The following is a description of a gene set: Genes up-regulated at the peak of an antigen response of naive CD8+ T-cells. from publication Goldrath AW, Luckey CJ, Park R, Benoist C, Mathis D (PMID 15548615) studied in species Mus musculus Mouse Gene Set: GOLDRATH_ANTIGEN_RESPONSE Naive T cells proliferate independently of cognate antigen when introduced into lymphopenic hosts. Lymphopenia-induced proliferation depends on low-affinity MHC/self-peptide complexes and on IL-7. To elucidate the intracellular signals mediating this proliferation, we analyzed changes in gene expression in naive CD8+ T cells at different times after their transfer into a lymphopenic environment. The genes induced in response to lymphopenia were largely an attenuated subset of those turned up by full antigenic stimulation, including genes related to cell cycling, whereas excluding genes specifically associated with effector activity. After the initial phase of proliferation in an empty compartment, the naive T cells adopted a stable pattern of gene expression similar to that of antigen-experienced memory cells. Thus, T cells proliferating in lymphopenic hosts do not exhibit a unique gene-expression profile, instead relying on traditional signals for this antigen-independent proliferation; this process ultimately results in differentiation to authentic memory cells., and this is the list of marker genes: Myo1f, Lgals1, Cdk2ap1, Tbl2, Trappc1, Lgals3, Hopx, Vcl, Ccdc50, Tmem97, Kpna2, Rfc5, Tk1, Rbm3 (NCBI Gene Id 72067), Perp, Chek1, Ccnb2, Arl5a, Top2a, Ptger4, Siva1, Emp3, Crmp1, Il2ra, Etfb, H2-Aa, Hat1, Gpr137b-ps, Zfp207, Errfi1, Lmnb1, Mis18bp1, Dock5, Batf3, Brip1os, Carhsp1, Rrm2, Ccl5, Topbp1, Gem, Incenp, Iglc2, Itm2b, Alad, Fasl, Lyl1, Tmem14c (transmembrane protein 14C), Stard10, 1810037I17Rik, Irf4, Lat2, Krtcap2, Igkv1-135, Lxn, Sqle, Ahnak, Plscr1, Syce2, Hspa2, Ezh2, Gzmk, Tceal9, H2az1, Fignl1, Bub1, Pim1, Cd44, Polr3k, Prim2, Slc31a1, H3c8, Cdk1, Stmn1, Tyrobp, Gnpda1, 2700099C18Rik, Clic4, Mcm10, Ran, Plk4, Ckap2, Lilrb4b, Cst3, Ifitm3, C3, Sgcb, Hip1r, Ugt1a2, Il18rap, Ttc39b, Anln, Serpinb9, Ggh, Mt2, Chil3, Cks1b, Ifng, Cdc6, Pgam1, Pclaf, Hmbs, Socs2, Cd24a, Itga4, Rell1, Scpep1, Cish, Mthfd2, Alas2, Klrg1, Slc66a3, Cks2, Rrm1, Rad51ap1, S100a13, Gm4739, Ccr2, Pola1, Plbd1, Ell2, Il18r1, S100a10, Rad21, Crybg1, Lig1, Psmc3ip, Ncaph, Igkv4-74, Tmem30a, Snx3, Gstt1, Prf1, Cdca5, Rnf227, Asf1b (NCBI Gene Id 66929), Itsn1 (intersectin 1 (SH3 domain protein 1A)), Cmc2, Spdl1, Ywhaq, Slc25a53, Ms4a1, Ccna2, Kifc1, Rhd, Napsa (napsin A aspartic peptidase), Ak3, Klrk1, Tktl1, Glrx, Runx2, Map2k3, Txn1, Pdcd1, H2-Ab1, Kif22, Ifi30, Plp2, Igkv8-19, Dhrs1, Bcl2a1a, Cma1 (chymase 1, mast cell), Cd48, Mapre2, Irf8, Unc119, Slc39a4, Acot7, Nptn, Rpa3, Slpi, Ctsd, Sp100, Cd74, Prdx4, Bag3, S100a4, Adam8, Ech1, H2-Q10, Cdca3, Ighv14-4, Litaf, Cdkn2c, Tpi1, Efhd2, S100a11, Plekhb2, Rora, Prim1, Gzmb, Mcm3, Cip2a, Hemgn, Plcg2, Tmem126a, Dtl, Itgax, Kif20a, Fancm, Kif11, E2f8, Tacc3, Sdhd, Ighv1-54, Lmna, Myl4, Mxd3, Jchain, Gmnn, Rnh1, Dennd5a, Adgre1, Ccr5, Cdc45, Serinc3, H2az2, Slc4a1, Rad51, Cisd1, Tmed7, Sypl1, Cyfip1, Cdkn3, Ctla2b, Rom1, Tmem37 (NCBI Gene Id 98701), N4bp1, Igkv6-15, Ctnna1, Ctla2a, H1f2, Pld4, Cdc20, Rhoq, Taf9 (TATA-box binding protein associated factor 9), Cdca8, F2rl3, Gzma, Aurka, Cd244a, Ttk, Racgap1, Emp1, Igkv4-73, Nusap1, Nrp1, Ube2t, Wee1, Nup62, Plk1, Iqgap3, Itgb1, Ccnf, F2r, Aspm, Slc4a7, Prdm1, H2-Eb1, Ccl4 (C-C motif chemokine ligand 4), Dhfr, Dna2, Gtse1, Tcf19, AU020206, Mdfic, Gsto1 (NCBI Gene Id 226190), Kif4, Mcm5, Ccl3, Skap2, Ighg2b, Cd68, Cbx5, Tyms, Ubl3, Ncf4, Brca1, Bhlhe40, Mgst1, Mcm4, Id2, Ier3, Alcam (activated leukocyte cell adhesion molecule), Rnaseh2b (NCBI Gene Id 68517), Ighv1-52, Capn2, Igkv4-79, Hmgn2, Mapk6, Eea1, BC004004, Il12rb1, S100a6, Gng10, Cited2, Anxa1, Cpox, Myadm, Ect2, Evi2a, Haus6, Arhgap21, Cenpa, Fyn, Kank3, Ebp, Gm4870 (predicted gene 4870), Dusp1, Trip13, Tpm4, M6pr, Slc2a3, Gadd45b, Ighv8-9, Tnfrsf9, Ccl9, Igkv17-127, Car2, Chaf1a, Car1, Mki67, Ly6c1, Dbi, Hbb-bs, Anxa2, Capg, Pcna, Pglyrp1, Serpina3g, Haspin, Fut7, Aurkb, Ighg3, Nudt4, Lag3, Cdc25c, Fen1, Ighg1, Casp1, Iglc1, Mad2l1, D17H6S56E-5, Ighv1-14, Mrpl18 (mitochondrial ribosomal protein L18), Reep5 (receptor accessory protein 5), H1f0, Igsf10, Tmpo, Nfil3, Sh3bgrl, Ctla4, Ybx3, Fhl2 (four and a half LIM domains 2), 1700097N02Rik, Dlgap5, Hpf1, St3gal6, Lrrc59, H2ax, Cxcr3 (NCBI Gene Id 12766), Atp5if1, Klra3, Serpinb6a, Snu13, Gcat, Kif2c, Gapdh, Birc5, Klrb1c, Lyn, Pgm2, Mt1, Odc1, Dstn, Ssx2ip, Abracl, Igkv4-68 (immunoglobulin kappa variable 4-68), Gzmm, Snx10, Rab11a, Eif1ax, Prc1, Fgl2, Anxa4, Casp3, Nek2